The following is a description of a gene set: Any process that activates or increases the frequency, rate or extent of fatty acid transport. species: Homo sapiens Human Gene Set: GOBP_POSITIVE_REGULATION_OF_FATTY_ACID_TRANSPORT, and this is the list of marker genes: MIF, P2RX7, PTGES, ACSL5, FABP3, EDN1 (NCBI Gene Id 1906), IL1B, TNFSF11, ACSL1, CYP4F2 (NCBI Gene Id 8529), OXT, TNFRSF11A, PLA2R1, PLA2G10, PLA2G4A, P2RX4, NTSR1 (NCBI Gene Id 4923), CYP4A11, AVPR1B, ERFE, PLA2G3